Given this list of marker genes Slx9, Nop9, Noc4l, Bysl, Riok1, Riok3, Riok2, Ftsj3, Nob1, Rrp1, Rrp1b, Nop14, Ltv1, here is a description of the gene set: A preribosomal complex consisting of 20S pre-rRNA, ribosomal proteins including late-associating small subunit proteins, and associated proteins; a precursor of the eukaryotic cytoplasmic small ribosomal subunit. Mouse Gene Set: GOCC_PRERIBOSOME_SMALL_SUBUNIT_PRECURSOR species: Mus musculus